Given this list of marker genes Cdkn1b, Cox7a2l, Cd3g, Rgs10, Hmgb2, Cdc42ep3, Rgs2, Stap1, Cd52, Cd3d, Nrp1, Stk17b, Ypel3, Pnrc1, Uba52, Cspp1, Sugt1, Inpp5k, Cd83, Pou2f2, N4bp2l1, Macf1, Ucp2, Btg2, Zfp36l1, Arid1b, Zbtb20, Smpdl3a, Tnfaip3, Cxcr4, Mxd4, Sh3kbp1, Pold4, Dusp1, Il7r, Srgn, Cyth3, Lbh, Ift80, Smc4, H2az2, here is a description of the gene set: Genes negatively differentially expressed in cell type: Treg upon treatment with cytokine: IL-15 in mouse lymph nodes in vivo. from publication Cui A, Huang T, Li S, Ma A, Pérez JL, Sander C, Keskin DB, Wu CJ, Fraenkel E, Hacohen N (PMID 38057668) studied in species Mus musculus Mouse Gene Set: CUI_TREG_IL15_RESPONSE_DN Cytokines mediate cell-cell communication in the immune system and represent important therapeutic targets. A myriad of studies have highlighted their central role in immune function, yet we lack a global view of the cellular responses of each immune cell type to each cytokine. To address this gap, the authors created the Immune Dictionary, a compendium of single-cell transcriptomic profiles of more than 17 immune cell types in response to each of 86 cytokines (>1,400 cytokine-cell type combinations) in mouse lymph nodes in vivo. A cytokine-centric view of the dictionary revealed that most cytokines induce highly cell-type-specific responses. For example, the inflammatory cytokine interleukin-1β induces distinct gene programmes in almost every cell type. A cell-type-centric view of the dictionary identified more than 66 cytokine-driven cellular polarization states across immune cell types, including previously uncharacterized states such as an interleukin-18-induced polyfunctional natural killer cell state.